Given this list of marker genes DUSP8, DUSP6, DUSP16, DUSP10, DUSP9, DUSP7, here is a description of the gene set: Human Gene Set: GOMF_MAP_KINASE_TYROSINE_PHOSPHATASE_ACTIVITY Catalysis of the reaction: MAP kinase tyrosine phosphate + H2O = MAP kinase tyrosine + phosphate. studied in species Homo sapiens